Given this list of marker genes ABL1, EGLN1, PDXP, PRMT8, CHMP2B, CLN3, CTTNBP2, BAIAP2, RHOB, MRTFB, RHOA, KIF5B, CYFIP1, AMOT, ITSN1, EPHA4, CAMKV, ZDHHC17, AGAP1, STRN4, here is a description of the gene set: Human Gene Set: GOBP_REGULATION_OF_MODIFICATION_OF_SYNAPTIC_STRUCTURE species: Homo sapiens Any process that modulates the frequency, rate or extent of modification of synaptic structure.